Given this list of marker genes CCR9 (C-C motif chemokine receptor 9), DNAJB6, CLYBL, NEDD4, NFKBIA, MALT1, HIP1, ZFP36, ERN1, PCSK1, FURIN, KCNQ5, TNFSF11, ITGA4, SAMSN1, MAPK8IP1, ODC1, SNX18, ITPRIPL2, ARL4A, RYK, DNAJC6, DHRS3, CCN4, EHD1, CDKN1A, ITGB5, ARAP2, ARL5B, ELL2, IRF2BP2, NFKBIZ, PPFIBP1, APOBEC1, NR3C1, RPS6KA5, RGS2, MYO6, ANXA1, STAT4, UHRF2, PADI2, KRT18, STX2, IL1RL1, DENND4C, IL13 (NCBI Gene Id 96500), EVI5, GFI1, BSPRY, PRKAB2, CASS4, IL18RAP, COBLL1, FEM1C (fem-1 homolog C), CHSY1, HIP1R (NCBI Gene Id 9026), DST, VPS37B, TMPRSS11E, PTPN13, PPP2R3A, CNOT6L, ID2, IMPACT, SRXN1 (NCBI Gene Id 140809), NR4A1, KIF5C, IMPA2, PLK3, ACOT7, TIGIT, SEMA4C (NCBI Gene Id 54910), TTBK2, LIF, AHNAK, NAPSA, GATA3, NSMAF, PLCB3, CYSLTR2, IDH3A, IRS2, ADCY8, CCL5, PMAIP1, MYO1E, TEX2, CREM, IPMK, SEC24D, IL10RA, MAFG, TOX2, LRRC49, RNF125, ZC3H12A, CXCR6, CCRL2, XCL1, KCNK5, FAM135A (family with sequence similarity 135 member A), ITGAV, SYTL2, ICA1, UTF1, ANTXR2, GRAMD1C, FAM107B, TNFRSF9, PPP1R16B, SC5D, SLC16A6, TRIM36, RAP1GAP2, TUBB6, TJP2, ALCAM, IER3, SQLE, ENKUR, CENPL, VCL, SLA, KLRG1, ATF3, CISH, IL18, ANXA2, INSIG1, FOSB, ASB2, LDLR, COQ10B, AKAP12, RNF43, TADA2A, LRRN4, DENND4A, MIR155, FAM185A, DGAT1, MIR23A, KCTD12, SPTY2D1, TNFRSF18, BAMBI, MFSD6, VAMP7, SEPTIN8, PLSCR4, HEXIM1, SEMA6D, CABYR, NXT2, HRH4, ISY1, BTG2, VCAM1 (NCBI Gene Id 7412), SERINC3, DNAJC12, EMB, PHKA1, SCP2, SLC39A4, MDFIC, STK39, DDX3X, DGKI, SEPTIN11, PLOD2, KCNA4, MAPKBP1, ST6GALNAC3, GPR183 (NCBI Gene Id 1880), ASNS, CDR2, SUSD2, PBX3, NMUR1, LONRF3, here is a description of the gene set: from publication Ramirez K, Chandler KJ, Spaulding C, Zandi S, Sigvardsson M, Graves BJ, Kee BL (PMID 22608498) Human Gene Set: GSE37301_MULTIPOTENT_PROGENITOR_VS_LYMPHOID_PRIMED_MPP_DN studied in species Homo sapiens Genes down-regulated in multipotent progenitors (MPP) versus lymphoid primed MPP cells. Expression profiling of Rag2-deficient Ets1++ and Rag2-deficient Ets1-- mature NK cells and WT bone marrow progenitors, WT T cells, and WT Pro B cells